Given this list of marker genes H3-3B, FIRRE, MACROH2A2, LRIF1, PCGF5, PCGF3, MACROH2A1, SMCHD1, XIST, CDK2, H3-3A (NCBI Gene Id 3020), SIN3B, H2AZ1, here is a description of the gene set: The sex chromosome present in both sexes of species in which the male is the heterogametic sex. Two copies of the X chromosome are present in each somatic cell of females and one copy is present in males. studied in species Homo sapiens Human Gene Set: GOCC_X_CHROMOSOME